Given this list of marker genes SNCA, DUOXA2, DUOXA1, NNT, SOD2, ZNF205, here is a description of the gene set: Human Gene Set: GOBP_POSITIVE_REGULATION_OF_HYDROGEN_PEROXIDE_METABOLIC_PROCESS Any process that increases the frequency, rate or extent of the chemical reactions and pathways involving hydrogen peroxide. studied in species Homo sapiens